The following is a description of a gene set: Endoplasmic retuculum (ER) stress response (caused by tunicamycin) genes dependent on CHOP. Unfolded and malfolded client proteins impose a stress on the endoplasmic reticulum (ER), which contributes to cell death in pathophysiological conditions. The transcription factor C/EBP homologous protein (CHOP) is activated by ER stress, and CHOP deletion protects against its lethal consequences. We find that CHOP directly activates GADD34, which promotes ER client protein biosynthesis by dephosphorylating phospho-Ser 51 of the alpha-subunit of translation initiation factor 2 (eIF2alpha) in stressed cells. Thus, impaired GADD34 expression reduces client protein load and ER stress in CHOP(-/-) cells exposed to perturbations that impair ER function. CHOP(-/-) and GADD34 mutant cells accumulate less high molecular weight protein complexes in their stressed ER than wild-type cells. Furthermore, mice lacking GADD34-directed eIF2alpha dephosphorylation, like CHOP(-/-) mice, are resistant to renal toxicity of the ER stress-inducing drug tunicamycin. CHOP also activates ERO1alpha, which encodes an ER oxidase. Consequently, the ER of stressed CHOP(-/-) cells is relatively hypo-oxidizing. Pharmacological and genetic manipulations that promote a hypo-oxidizing ER reduce abnormal high molecular weight protein complexes in the stressed ER and protect from the lethal consequences of ER stress. CHOP deletion thus protects cells from ER stress by decreasing ER client protein load and changing redox conditions within the organelle. Human Gene Set: MARCINIAK_ER_STRESS_RESPONSE_VIA_CHOP studied in species Mus musculus from publication Marciniak SJ, Yun CY, Oyadomari S, Novoa I, Zhang Y, Jungreis R, Nagata K, Harding HP, Ron D (PMID 15601821), and this is the list of marker genes: PPAN, AMPD3, CLCN3, SOAT2, KITLG, PTX3, POLR1A, DDIT3, PARD6A (NCBI Gene Id 50855), PPP1R15A, ERO1A, CA6, RAD1, STBD1, ADH7, ETS2, WFS1, PTRH2, MTM1, CDCA7, CHKA, LONP1